The following is a description of a gene set: studied in species Homo sapiens IL-10 or IL-6 stimulation of control 129xC57BL/6 murine bone marrow derived macrophages in the presence of LPS. We used microarrays to detail the global programme of gene expression changes in response to IL-6 or IL-10 stimulation in the presence of lipopolysaccharide. BMDMs were isolated from control, IL-6-/-, and IL-10-/- mice on a 129XBL/6 mixed background mice and differentiated in the presence of CSF-1 for 6-7 days. Cells were scraped and plated in 6 well plates at 2x10e6/well. Cells were washed with complete DMEM and rested for 1-2 hr before stimulation with combinations of IL-10 (10 ng/ml), IL-6 (2 ng/ml) or LPS (100 ng/ml) for 45 min or 180 mins. Complete biological replicates were performed. Human Gene Set: GSE5589_WT_VS_IL10_KO_LPS_AND_IL6_STIM_MACROPHAGE_45MIN_DN Genes down-regulated in bone marrow-derived macrophages at 45 min of stimulation by IL6 and LPS: wildtype versus IL10 knockout. from publication El Kasmi KC, Holst J, Coffre M, Mielke L, de Pauw A, Lhocine N, Smith AM, Rutschman R, Kaushal D, Shen Y, Suda T, Donnelly RP, Myers MG Jr, Alexander W, Vignali DA, Watowich SS, Ernst M, Hilton DJ, Murray PJ (PMID 17114459), and this is the list of marker genes: FBXO43, DNM2, C1QTNF9, PXT1, SRPRA, PEG3, LONRF2, FRMD3, MAPKAPK5, TRAPPC9 (NCBI Gene Id 83696), PLXDC2 (plexin domain containing 2), TRIT1, MID2, KLK5 (kallikrein related peptidase 5), CST11, NOSTRIN, SLC37A2, ABRA, SIGLEC1, SENP7, TALDO1, CBLN2, IRAK4, SLC7A10, STARD5, MTNAP1, PCBP2, COMMD7, WIPF2, TMEM106C, C11orf54 (NCBI Gene Id 28970), ARHGEF10, RHBDL1, BTF3, FASLG, SLMAP, LMO4, FKRP, PITPNM2, NSG2, KCNN1, ATP8A2, SSBP4, MLC1, TIE1, RALA (RAS like proto-oncogene A), EFCAB2, PRORP, CPT1A, KLF7, HPGDS, CA12, POU5F2, PCDH17, LPCAT3, BEST2, ZFP57, IL16, NCK1, COPS7A, SNRNP48, RPL36A, FGF17, AIMP1, BCL11B, TRAPPC12, VPS26C, ARHGEF38, FAM118B, WAS, NIPBL, TRIM62, NEUROD1, SPTB, ACAA2, SHISA9, PID1, EVA1C, PIAS1, RITA1, KCNQ3, KCNK12, ELK1, IGF2BP3, PTP4A2, PRSS54, PCDHAC1, ST8SIA3, TECTA, PDX1, SNX27, PRKCI, MPLKIP, RNF216 (ring finger protein 216), TMEM242, HINT3, AXL, C4BPA (complement component 4 binding protein alpha), EGFL7, WBP2, PRR9, TNRC6A, S100A14, FOS, LFNG, RPL4, ATP1A2, MFAP3, AGPAT4, GLDC, EMX2OS, ABCD2, UBXN1, OSBP2, PRDX3, ITGAL, KCNAB3, RPL31, ARHGEF33, ACTR1B, SKIL, N4BP1, MLYCD, PKDREJ, ANGPTL4, LRP5, FAM83F, ROCK2, HECTD1, KIF1C (kinesin family member 1C), TOX4, ABHD12, SLC16A7, TMEM104, RPL27, MYOM3, ERG, FRMD5, CLDN8, ZHX1, SEMA3E, KLRC1, MBIP, KPNA3, THUMPD3, EPCAM, TMEM82, SLC28A3, CARM1, HEBP1, LIMS2, FAM168A, XRCC4, NPY2R, PTEN (NCBI Gene Id 8037), PLPPR4, EEF2, SLC5A2, WDR47, TBC1D8, TBL1X, THUMPD2, ZNF541, MTERF4, SLC25A18, TNFRSF21, METTL13, EPHX2, FBXL19, VAMP4, WDR33, TYW1, NKIRAS2, S100A3, PPP2R2B, HLF, ATP6V0A4, EXOC3L2, KANSL1, TRIM32, RPLP2, ADORA3, GPCPD1, KRTAP8-1, OTX1, TGFB1, TAB3, TRMT1, CHST6, HOXA3, CLEC10A, ADNP, FBXL4, LYRM2, HADHA, STAG2, MYOG, GATAD2B, PCNX2, SASH3